The following is a description of a gene set: from publication Ng SY, Yoshida T, Zhang J, Georgopoulos K (PMID 19345118) Genes down-regulated in megakaryo-erythrocyte progenitors versus granulo-monocyte progenitors. Regulation of lineage potential and transcriptional priming by Ikaros. New insight is provided into a bivalent regulation of lineage priming in the HSC and its lympho-myeloid restricted progeny the LMPP by the lymphoid lineage-determining factor Ikaros Whereas Ikaros is responsible for the activation of a cascade of lymphoid expression programs and for the establishment of lymphoid potential from the HSC to the LMPP it is also responsible for the repression of stem cell and erythroid genetic programs that are incompatible with further lineage restrictions emanating from the LMPP Human Gene Set: GSE15330_MEGAKARYOCYTE_ERYTHROID_VS_GRANULOCYTE_MONOCYTE_PROGENITOR_DN studied in species Homo sapiens, and this is the list of marker genes: CD200R1, CABLES2, SRGN, NT5DC3, ITGAV, NFIC, MED21, SLC43A3, PSMD7, CERS4, LBP, CYRIB, INSL5, MAF, RRAD, DPCD, MAGED1, RIOX2, KLF6, ST6GALNAC6, TMED3, CHM, CSTB, SPRED1, BEX2, SGK1, RNASEH2C, MTSS1, CASP7, GNB5, TEX264, ARHGAP12, NUBP2, EXT1, DNAJC21, AFG2A, ELOC, SKIL, BLCAP, CST3, RNF130, KCNN3, CTTN, IER3, BMP1, DPY30, CMTM6, SMARCD1, MYO1C, ARL2BP, PRNP, EXOC8, SHBG, TMX1, PELI2, LTA, AMPD2, NIBAN2, RPRD1B, SPATS2, PPP2CA, CRK, IL10, RELL1, PPIB, PABIR1, ANXA3, BCR, RPLP0, TAB2 (NCBI Gene Id 23118), ADA, TAX1BP3, RAB18, EMD, GGA2, EFNB2, HRAS, ACVR2A, SPTAN1, SERF1A, BCL3, MYO1G, PLEKHF2, LGALS4, BAG1, MPHOSPH6, TIMP2, IL18RAP, TRAK1, HECTD1, CDC6, SLC16A6, CTNND2, CTDSPL, HASPIN, TM9SF1, UBL4A, SS18, SLC25A11, UIMC1, ILK, TMEM106C, AFF1, ECI2, FBXO45, ABHD4 (NCBI Gene Id 63874), DEGS1 (NCBI Gene Id 8560), RORC, GABRE, CBX6, CAPRIN2, KLF15, FCHO1, MAP2K3, ADGRA3, LRRC8C, POLR3F, RABAC1, EFEMP2 (NCBI Gene Id 30008), RAB6A, YIF1A, PARP16, TTR, STAB1, DHX32, AGPAT3, IPO5, CXCL10, NME4, RALB, ACTR1A, B3GNT8, BTBD17, KMT5A, KLRK1, ABCB10, JAK3, GMEB1, SNX20, ZFP90, DEDD, CENPF, PEA15, ESYT1, DPPA2, SLC25A30, SLC16A3, CHST2, PAGR1, RAP1B, TOR2A, MITF, IL1R1, CYP1A1, ATP10A, HSD11B2, NUDT5, NT5C, SPINK4, SMAP1, CIAO2B, EGR2, ANGPTL2, LZTR1, DNAJC18 (DnaJ heat shock protein family (Hsp40) member C18), CCDC88C, SOCS1, VPS29 (NCBI Gene Id 51699), MRPL33, DPM2, RRAGD, SPSB3, RECK, SLC39A8, PEX11A, TPM3, CAMKK1, DDIT4, SPSB1, CRMP1, ALDH9A1, SLC35F6, COX7A1, MYO10, FBXL3, PRPH, GSTT2, FES (FES proto-oncogene, tyrosine kinase), TXK, TSPAN6, MRPL30, SRGAP3, ARHGAP21, UBQLN1, OMP, SQOR, RNF26, GNPDA1, ARF6, CHD7